The following is a description of a gene set: Gene Silencing by RNA species: Homo sapiens Human Gene Set: REACTOME_GENE_SILENCING_BY_RNA, and this is the list of marker genes: MAEL, H2BC10, H2AC8, H2BC12, POLR2A, TDRD12, H4C5, NUP58, H4C9, H2BC26, H2BC5, PIWIL2, DICER1, H2AC4, ANG, TDRD9, TDRKH, RAE1 (ribonucleic acid export 1), TPR, H3C6, H4C14, H4C11, NUP107, H3C15, NUP85, H2BC21, PIWIL4, MYBL1, H4C12, H4C2, H2AX (H2A.X variant histone), H3C1, POLR2G, NUP37, AGO2, TARBP2, NUP93, H3-3B, NUP42, PRKRA, FKBP6, ELAC2, NUP133, DGCR8, H2BC8, TNRC6B, NUP88, H3C4, PIWIL1, POLR2L, H2AC18, POLR2D, H3C11, H2BC6, H3C12, H2AB1, NUP43, AGO4, H2AC14, NUP98, H2BC7, H2BC15, H2BC13, H2BC17, DDX4, H3C8, H2AC20, H4C6, NUP50, SEC13, H3C3 (H3 clustered histone 3), H2BC11, POLR2H, XPO5, NDC1, H2AZ2, POLR2I, AAAS, NUP35, H2BC9, H2AJ, H4C8, ASZ1, POLR2B, AGO3, NUP188, H2BC3, RANBP2, DROSHA, H4C3, NUP155, NUP153, TDRD1, H3C14, H2BC4, TSN, H4C15, SEH1L, POLR2J, TNRC6A, NUP205, POM121, H4C1, H2BC12L, H2AC19, H2AC7 (NCBI Gene Id 3013), H3C13, H2BC1, H3C10, TDRD6, TSNAX, H2BC14, NUP210, POLR2F, BCDIN3D, NUP54, H2AC6, POM121C, H4C13, POLR2K, AGO1, IPO8, H4C16, NUP62, H3C7, H3C2, MOV10L1, MIR23B, PLD6 (NCBI Gene Id 201164), POLR2C, NUP214, HENMT1, TNRC6C, H3-3A, RAN, HSP90AA1, H4C4, NUP160, POLR2E